The following is a description of a gene set: Reactome Pathway: Nucleotide-binding domain, leucine rich repeat containing receptor (NLR) signaling pathways part of: Innate Immune System This event has been computationally inferred from an event that has been demonstrated in another species.<p>The inference is based on the homology mapping from PANTHER. Briefly, reactions for which all involved PhysicalEntities (in input, output and catalyst) have a mapped orthologue/paralogue (for complexes at least 75% of components must have a mapping) are inferred to the other species. species: Mus musculus electronically inferred by orthology from the curated human pathway, and this is the list of marker genes: Casp1, Bcl2l1, Sugt1, Tab2, Casp9, Birc3, Map2k6, Pstpip1, Panx1, Ube2v1, Mefv, Cyld, Txn1, Rps27a, Tnfaip3, Ube2n, Tab1, Casp2, Mapk11, Nlrp3, Casp4, Ubb, Tab3, Mapk13, Casp8, Mapk12, P2rx7, Aim2, Mapk14, Pycard